The following is a description of a gene set: The process whose specific outcome is the progression of the lacrimal gland over time, from its formation to the mature structure. The lacrimal gland produces secretions that lubricate and protect the cornea of the eye. Human Gene Set: GOBP_LACRIMAL_GLAND_DEVELOPMENT species: Homo sapiens, and this is the list of marker genes: FGF10, PAX6 (NCBI Gene Id 5080), SOX9, FOXC1, FGFR2, IGSF3, SOX10